The following is a description of a gene set: studied in species Homo sapiens mouse primary BMDCs were stimulated with tlr ligands and gene expression changes were profiled on Affymetrix arrays Human Gene Set: GSE17721_CTRL_VS_GARDIQUIMOD_24H_BMDC_UP Genes up-regulated in comparison of control dendritic cells (DC) at 24 h versus those stimulated with Gardiquimod (TLR7 agonist) at 24 h. from publication Amit I, Garber M, Chevrier N, Leite AP, Donner Y, Eisenhaure T, Guttman M, Grenier JK, Li W, Zuk O, Schubert LA, Birditt B, Shay T, Goren A, Zhang X, Smith Z, Deering R, McDonald RC, Cabili M, Bernstein BE, Rinn JL, Meissner A, Root DE, Hacohen N, Regev A (PMID 19729616), and this is the list of marker genes: INSR, TFB2M, SNAP23, CDK16, VDAC1, UBL4B, TP63, ADCY7, PTMS, COMMD4, TMEM186, TMEM14C (transmembrane protein 14C), EPS15, IP6K1, FIS1, CARHSP1, JARID2, CRYZ, PHF13, ACO1, PTPRA, ZNF277, TAX1BP3, ARRB1, SEPTIN8, TPK1, WASHC2A, GALNT2, DDX3X, GAB3, TGFBR1, HOMER1, B3GNT8, ABCB7, LDLRAP1, ADARB2, NDUFA10, IQGAP1, PLXNB3, B3GNTL1, CSF3R, UBXN1, CEP250, GRN, ERBIN, RUFY3, HELZ, CD164, ERGIC3, TRPT1, IFT46, ACO2, GCNT1, CHDH, GOLM1, DAB2, CXCR4 (NCBI Gene Id 93405), IL6ST, ACAT1, DTNBP1, NSMCE2, C8G, MRPL23, TNRC6B, CD22, CHCHD7, BPGM, HAUS8, PTS, UBE2B, MBP, NQO2, CEACAM21, ATRAID, P2RY12, SIRT3, HMGCS1, DHCR24, TGM2, MRPL42, C6orf62, GNPDA1, STARD4, SLC38A5, C6orf89, BMP5, MCEE, PRDX6, PARVG, VRK1, FHIP2A, PCNX3, KCNK4, UBALD2, MKNK2, MACROD1, EEPD1, LZTR1, ZC3H11A, FRMD4B, SNX14, EIF3F, CYP51A1, BUB1, CCNQ, APOC4, CTSA, SCML2, IFI30, STXBP2, NDUFA13, PGP, P2RX4, CCNI, PDLIM1, HPGDS, RAB28, PEPD, SYT9, PAM, RPS3, FUOM, SSBP4, HEBP1, STS, RAC1, ANKH, GSC, KRT7, CIITA (class II major histocompatibility complex transactivator), CPA1, ARPC1A, LTBP3, CAPN15, SPSB2, HIVEP2, ZNF689, CD300LD, ABTB1, RASSF5, N4BP2L1, GAPDHS (glyceraldehyde-3-phosphate dehydrogenase, spermatogenic), ASF1B, POLR1C (NCBI Gene Id 9533), SMARCAD1, MAPK11, LAMTOR3, EVI5, CYP4F3, ARHGAP45, NSMF, SLC44A3, CBS, MMP19, CMIP, ENPP1, RNF38, MYOF, SMIM11, RDM1 (RAD52 motif containing 1), CIDEB (cell death inducing DFFA like effector b), TFEB, FCAMR, MRPL36, GALC, MANBA (NCBI Gene Id 4126), PALD1, TMEM242, YEATS4, SYF2, CD300C, RPL34, TMEM141, ADAM15, SELP, RALBP1, TAF4, MFAP1, ANKRD10, TPRA1, TF, SCAMP1, SLC25A39, TFAP2A, CC2D1A, ASPRV1, ELOVL6, MVK, SH3RF1, G6PC1, TBL1X, RAD1, CDC20, DGLUCY, PIAS3, MAU2, PNPLA6, IL6R (interleukin 6 receptor), PNRC1, KLHL9